Given this list of marker genes Acot8, Eci2, Ehhadh, Acox1, Acot4, Hsd17b4, Slc27a2, Decr2, Abcd1, Acaa1b, Mlycd, here is a description of the gene set: species: Mus musculus Mouse Gene Set: REACTOME_BETA_OXIDATION_OF_VERY_LONG_CHAIN_FATTY_ACIDS Beta-oxidation of very long chain fatty acids